Given this list of marker genes SULT2B1, SULT1C2, TPST1, LIAS, CHST12, TPST2, CHST4, HS3ST5, CHST10 (NCBI Gene Id 9486), CHST15, CHST3, MOCS3, SULT4A1, MOCS2, OXCT2, WSCD1, ACAA1, GAL3ST4, UST, CHST8, CHST1, SULT6B1, SULT1A2, HS3ST6, HS6ST1, TST, ACSM3, MOCOS, TRMU, CHST2, GAL3ST2, CHST5, CHST11, HS3ST3B1 (heparan sulfate-glucosamine 3-sulfotransferase 3B1), MPST, SUGCT, HS3ST3A1, SULT1C4, CHST13, SULT1A4, WSCD2, SULT1A3, TSTD1, CHST14 (carbohydrate sulfotransferase 14), NDST4, CHST7, CHST6, SULT1C3, HS6ST2, HS2ST1, SULT1E1, CDK5RAP1 (CDK5 regulatory subunit associated protein 1), SULT1B1, HS6ST3, NDST3, NDST2, NDST1, GAL3ST3, GAL3ST1, CDKAL1, CTU2, NFS1, HS3ST2, SULT1A1 (sulfotransferase family 1A member 1), CHST9, HS3ST4, OXCT1, SULT2A1, HS3ST1, DSEL, here is a description of the gene set: studied in species Homo sapiens Catalysis of the transfer of a sulfur-containing group from one compound (donor) to another (acceptor). Human Gene Set: GOMF_TRANSFERASE_ACTIVITY_TRANSFERRING_SULPHUR_CONTAINING_GROUPS